Given this list of marker genes MYOCD, ISL1, ITGB1, GREM1, REST, NRG1, NOTCH1, PRICKLE1, TBXT, TBX2, SRF, RBPJ, here is a description of the gene set: The process in which a relatively unspecialized cell acquires specialized features of a cardiac myoblast. A cardiac myoblast is a precursor cell that has been committed to a cardiac muscle cell fate but retains the ability to divide and proliferate throughout life. species: Homo sapiens Human Gene Set: GOBP_CARDIAC_MUSCLE_CELL_MYOBLAST_DIFFERENTIATION